Given this list of marker genes GPATCH8, ITGA1, ZBTB8A, CALD1, RBBP4, RAB3IP, KLB, PDE4C, IKZF3, EMP2, WNT7B, PATE2, ORAI2, CPEB1, MAVS, TRIM49D1, AVL9, LINC02898, YPEL1, SNAP29, CYP20A1 (cytochrome P450 family 20 subfamily A member 1), TOE1, SPOCK1, SLC25A23, NLGN1, HRH4, URM1, TIMM50, TCEANC2, CAMK1D, TRIM51, GK5, SPN, IVD, OPA3, FGF11, MYCL, PRDM5, PAG1, AGAP1, HIP1, ATXN3, MTCL2, GGT7, YME1L1, PLA2R1, CTSA, POU4F1, DBT, LRRC57, MTX3, PTAFR, SUDS3, ZNF865, GATAD1, C11orf58, LGI1, TMEM199, PRR11, COL4A3, CENPU, DGKH, CORO1C, ARHGEF6, FNDC9, CSNK1G1, MGARP, TMEM183BP, MCTS1, TCN1 (NCBI Gene Id 6947), CELF4, AAK1, NAA50, CYFIP2 (cytoplasmic FMR1 interacting protein 2), TMEM37, ZNF577, PTP4A2, DCAF10, WDR59, VLDLR, VPS53, ABHD2, TMEM183A, PLEKHG4B, FFAR2, VCF2, MDM1, KIAA1614, SLC43A2 (solute carrier family 43 member 2), CACNA2D1, SUSD5, MASP1, COPG2, CRCP, CCNT1, ODF2L, SLC7A14, LASP1, ICA1L, PIAS2, GLCE, KCNMA1, ABL2 (NCBI Gene Id 27), LRRC74B, ANAPC16, NUBPL, GPD2, ROCK2, ETS1, PPIC, KIAA1328, SMIM14, NR3C1, PDP2, CTNS, SPATS2, LETM2, DOCK5, STON2 (NCBI Gene Id 85439), NFATC2, ABHD18, BOC, ESRP1, ATCAY, WDFY1, METTL21A, POLH, C19orf18, TRMT10C, CACNA1E, C5AR1, APTX, TMPO, CACNG8, TLCD2, ZNF721, SPRYD4, CTSB, here is a description of the gene set: Genes predicted to be targets of miRBase v22 microRNA hsa-miR-619-5p in miRDB v6.0 with MirTarget v4 prediction scores > 80 (high confidence targets). from publication Chen Y, Wang X (PMID 31504780) studied in species Homo sapiens Human Gene Set: MIR619_5P